The following is a description of a gene set: Human Gene Set: HP_EPIDERMAL_ACANTHOSIS species: Homo sapiens Diffuse hypertrophy or thickening of the stratum spinosum of the epidermis (prickle cell layer of the skin). Epidermal acanthosis, and this is the list of marker genes: AKT1, KRT10 (keratin 10), COL14A1, ALOXE3, SLC27A4, ATP2A2, LIPN, ELOVL1, POGLUT1, WNT10A, GJA1, KRT13, EGFR, ENPP1, CAST, EXPH5, KRT9 (NCBI Gene Id 3857), KDSR, NLRP1, GJB6, GJB3, SMARCAD1, TGM1, DSP, AAGAB (NCBI Gene Id 79719), IL36RN, CSTA, SERPINB7, MBTPS2, GRHL2, JUP, CIB1, GJB2, CDSN, SLURP1, KRT1, NIPAL4 (NIPA like domain containing 4), SERPINB8, CYP4F22, LORICRIN, DSC3, ZNF750, KRT6C, KRT74, DSG1, CLDN1, NSDHL, KLK11, KRT16, IL1RN, CERS3 (ceramide synthase 3), PERP, CARD14, ALOX12B